Given this list of marker genes Dock11, Coro1a, Casp3, Vpreb1a, Ppp2r1a, Ppp3cb (protein phosphatase 3, catalytic subunit, beta isoform), Skil, Sash3, Tsc22d3, Bbip1, Rag1, Ikbkg, Sh2b2, Gpr174, Gpam, Gapt, Tgfb1, Bax, Rc3h1, Tnfrsf13c, P2rx7, Aim2, Tnfrsf17, Ppp2r3c, Fas, Foxn1, Gpr15lg, Abl1, Traf3ip2, Stat5b (NCBI Gene Id 20851), Rc3h2, Sos2 (SOS Ras/Rho guanine nucleotide exchange factor 2), Foxp3, Wdr37 (WD repeat domain 37), Pmaip1, Gimap3, Zc3h8, Tnfaip3, Tgfb2, Sos1, Tnfsf4, Spta1, Bbs4, Fadd, Slc46a2, Tnfrsf4, Bcl2l11, Lyn (NCBI Gene Id 99963), Hif1a, Tnfsf13b, Mif, Vpreb1b, Akt1, Bak1, Pirb, Ahr (NCBI Gene Id 193333), Sit1, Mef2c, Il2ra, Pacs1, Caml, Tcirg1 (T cell, immune regulator 1, ATPase, H+ transporting, lysosomal V0 protein A3), Ccnb2, Pik3cd, Il2, Cd47, Spns2, Ada, Slc40a1, Cd44, Nckap1l, Lgals2, Gimap5, Jak3, Cd24a, Prdx2, Stat5a, Ripk3, Slc39a3, Bcl10, Ikbkb, Lat, Ppp2ca, Il20rb, Rps6, Il7r, Dock10, Tnfrsf13b, Lmo1, Enpp1, Cd74, Siva1, Dnaja3, Chst3, Bcl2, Bcl2a1a, Pkn1, here is a description of the gene set: The process of regulating the proliferation and elimination of lymphocytes such that the total number of lymphocytes within a whole or part of an organism is stable over time in the absence of an outside stimulus. studied in species Mus musculus Mouse Gene Set: GOBP_LYMPHOCYTE_HOMEOSTASIS